Given this list of marker genes GALR1, TMEM106C, ZMYND8, TARS2, GOLPH3L, TMEM191C (NCBI Gene Id 649064), MRPL47, DTNBP1, PEBP4, FANCD2OS, SEC24B, DKKL1, MMP11, ARHGEF10, CDV3, ANXA9, QRICH1, LRRC26, TUBB1, MRM1, UFSP2, ADCY5, NUDT6, PKMYT1, NRIP1, PKN3, TMC5, C11orf52, PHPT1, SQLE, NPR2, TSPAN7, CD44, TAF4B, MCCC2, HMGN5 (NCBI Gene Id 79366), TM4SF5 (NCBI Gene Id 9032), PCSK4, TMPRSS5, PLA2G5, ZDHHC19, ISCA2, APOBEC4, RWDD1, FAM53A, HEXIM2, UBE2Q1, LITAF, LMNB2, PCARE, APPBP2 (amyloid beta precursor protein binding protein 2), GAREM1, CTSF, PCLO (piccolo presynaptic cytomatrix protein), SMAD6, AFG2B, RPLP0, SLC18A1, NAIF1, AAGAB, EIF5A, CHAC1, PM20D1, CHEK2, SLC29A3, PPP5C, KDM8, FADS6, NDRG2, MAPK8, ALG8, SPAG4, PPAT, CTNNBL1, FAM111A, NFE2L2 (NFE2 like bZIP transcription factor 2), LRRC8D, ZNRD2, GNL3, PRPF40B, SLC6A6, CLSTN2, ADCY6, LCMT2, MCTP1, GGT7, MARCHF5, CIMAP1B, HCN3, TBC1D9, C8A, RPL23A, SGK3, PSMD1, MSRA, CDK2, CELF2, AUNIP, BCR, HSPA12B, GAPVD1, ZNF496, LGR6, GRN, TFDP1, TCEAL8, TBCEL, BBS10, MNAT1 (NCBI Gene Id 4331), GNPNAT1, FRRS1, UMPS, JPT2, EHMT2, FAH, RPL28, FBXW4, HACD1, PTPN20, CEND1, BBOF1, PIK3CD, CLDN3, MFAP2, CFAP68, TMPO, ELL, CCN1, SMG1, PRAMEF2, NME7, PGK2, DPP4, HPRT1, GADD45A, GALK1, KPNA7, TMA16, PIK3IP1, SF3A3, DLX1, PECR (NCBI Gene Id 55825), NRM, RALBP1, PA2G4, APLN, RAI1, SGCE, STAT5A, FIRRE, WDR91, IDUA, NCOR1 (nuclear receptor corepressor 1), CSDE1, ARSK, PRSS22, UVRAG, IL11RA, PDXK, P2RX5, TGM2, SIX5, SELENOP, CENPM, MORN4, CYP26A1 (cytochrome P450 family 26 subfamily A member 1), FNBP4, BRCA2, THOC3, CPA4, OR51E1, CAV2, SNHG8, BMP1, MZT2B (mitotic spindle organizing protein 2B), C1QBP, PINK1, LRRK2, GABRR1, SPATA3, PUS1, MIIP, HSPD1, STARD10, MRE11, PI4K2B, RTL8B, SMARCC2, ZNF629, TCEAL1, SETDB1, FAM170A, FOXRED2, PALLD, WDFY1, SEMA3C, ANKRD28, ECI1, EXO1, MTSS1, here is a description of the gene set: studied in species Homo sapiens Genes up-regulated in primary bronchial epithelial cells: control versus stimulated with IL17A. from publication Aujla SJ, Chan YR, Zheng M, Fei M, Askew DJ, Pociask DA, Reinhart TA, McAllister F, Edeal J, Gaus K, Husain S, Kreindler JL, Dubin PJ, Pilewski JM, Myerburg MM, Mason CA, Iwakura Y, Kolls JK (PMID 18264110) Human Gene Set: GSE10240_CTRL_VS_IL17_STIM_PRIMARY_BRONCHIAL_EPITHELIAL_CELLS_UP Primary HBE cells were stimulated with IL-22 and IL-17, and gene expression was studied using an Affymetrix platform microarray, in order to investigate which genes may be upregulated or downregulated in response to these cytokines. Of particular interest was the host defense genes such as antimicrobial peptides, which have been shown to be upregulated by IL-22 and IL-17 in skin keratinocytes.